The following is a description of a gene set: A tumor (abnormal growth of tissue) that arises from the soft tissue. The most common types are lipomatous (fatty), vascular, smooth muscle, fibrous, and fibrohistiocytic neoplasms. Human Gene Set: HP_SOFT_TISSUE_NEOPLASM studied in species Homo sapiens Soft tissue neoplasm, and this is the list of marker genes: COL4A5, COL4A6, BMPR1A, GREM1, NOTCH3 (notch receptor 3), PDGFRB, SPRED1, MUTYH, APC, POT1, CTNNB1, NAB2, STAT6